Given this list of marker genes CHST8, MAN2A1, FUCA1, CHST10, FUT8, MGAT2, FUT3, LHB, MAN2A2, CGA, here is a description of the gene set: Reactions specific to the complex N-glycan synthesis pathway studied in species Homo sapiens Human Gene Set: REACTOME_REACTIONS_SPECIFIC_TO_THE_COMPLEX_N_GLYCAN_SYNTHESIS_PATHWAY